The following is a description of a gene set: studied in species Homo sapiens The lipid bilayer surrounding a coated vesicle. Human Gene Set: GOCC_COATED_VESICLE_MEMBRANE, and this is the list of marker genes: AP1S2, CEMIP, AP3B2, APOE, CFTR, CNIH3, SYT1, AP1M2, SREBF1, AP2M1, TF, DIPK2A, USO1, VAMP4, SCAP, AP1S3, HLA-DRA, HSPA8 (NCBI Gene Id 3312), ATP6V1H, SEC23B, SYT9 (NCBI Gene Id 337992), PDCD6, SLC30A5, AP1G1, TGFA, RAB35, ADRB2, COPB2, LDLRAP1, LRP2, SYT2, CLTA, EREG, ATP6V0C, COPZ1, FZD2, ATP6AP2, AP2B1, TMED2, AP1B1, IGF2R, CIDEB, ATP6V1E1, RAB3A (NCBI Gene Id 96387), FOLR1, SLC17A7, VAMP8, MCFD2, SCYL1 (SCY1 like pseudokinase 1), HLA-G, HLA-DRB5, CNIH1, ARCN1, TGOLN2, RNASEK, CLTCL1, CD207, SH3GL2, CHRM2, NECAP1, AP2A1, GAD1, CD3D, EPS15, AP2A2, HLA-H, CLINT1, DBNL, SYT11, STON1, VAMP3, SAR1A, SEC23IP, SEC31B, HLA-B, ATP6V1G2, EPN1, VAMP7, HLA-DQB2, AP1S1, BTC, NECAP2, KDELR1, KLHL12, B2M, ATP6AP1, ATP6V1B2, ATP6V0D1, CD59, SEC24D, CLTB, CLBA1, ATP6V1A, FCGR1BP, RASSF9 (NCBI Gene Id 9182), HLA-DRB4, RAB5A, VTI1B, KIAA0319, APOB, MYO6, TMED7, HLA-DRB3, PEF1, STX5, ATP6V1C1, SLC18A1, HLA-DQA2, SEC31A, HLA-DQB1, AP1M1, SEC24B, TMED10, ADCY8, CD9, HLA-C, VMA21, SGIP1, HLA-F, EPN3, SLC2A8, LDLR, IL7R, CLTC, GRIA1, AP2S1, ENTHD1 (NCBI Gene Id 150350), HIP1, SEC24C, ATP6V1D, TYRP1, HLA-DRB1, SYNRG, COPA, DENND1A (NCBI Gene Id 79878), TBC1D5, AP1G2, EGF, WNT5A, ARC, SEC13, EPN2, EGFR, COPB1, AP3B1, TFRC, SLC18A2, SREBF2, HLA-DPA1, EPGN (NCBI Gene Id 255324), VTI1A, STX17, ATP6V1F, LMAN1, HLA-E, BTBD8, GOSR2, VAMP2, SCARB2, SAR1B, M6PR, SEC22B, HLA-DQA1, COPG2, FZD4, HIP1R, SEC23A, CRYZL2P-SEC16B, SEC16B, ATP6V0E2, NRGN, TMEM199, AP4B1, AVP, AFTPH, TEPSIN, STON2, GAD2, KDELR3, CD4, HLA-DPB1, NCALD, ATP6V0A1, HBEGF, HLA-A, DAB2, CD3G, KDELR2, COPG1, SEC16A, FZD5, FCGR1A, ATP6V0B, AREG, COPE, MYCBPAP, SEC24A, DNAJC5, SLC32A1, AVPR2, REEP6, COPZ2, SLC18A3, CD74, ROR2, TMED3, CNIH2